The following is a description of a gene set: Mouse Gene Set: GOCC_MULTIVESICULAR_BODY_MEMBRANE species: Mus musculus The lipid bilayer surrounding a multivesicular body., and this is the list of marker genes: Chmp3, Nsg1, Rab27a, Chmp4c (NCBI Gene Id 74324), Tmem9, Cd63, Abcb6, Laptm4b, Chmp2b, Atp13a2, Chmp1b, Chmp2a, Chmp1b2, Chmp4b, Slc9a8, Cd300lg, Nsg2, Chmp5, Chmp7, Chmp1a, Chmp6, Abca3, Pmel, Sorl1, Rab27b (NCBI Gene Id 80718), Gimap5, Hgs